Given this list of marker genes TNNI3, LRPPRC, ABCA3, SFTPB, PLXND1, NKX2-6, MYPN, EIF2AK4, KIF20A, MOGS, PRKAG2, HELLPAR, TTR, TBX1, FOCAD, SFTPC, MYBPC3, TNNT2, EPHB4, NAA10, FLNC, STOX1, FSHR, CORIN, CD46, CFH, MT-CYB (mitochondrially encoded cytochrome b), CFI, FLT1, here is a description of the gene set: studied in species Homo sapiens Human Gene Set: HP_PULMONARY_EDEMA Fluid accumulation in the lungs. Pulmonary edema